The following is a description of a gene set: species: Homo sapiens Genes predicted to be targets of miRBase v22 microRNA hsa-miR-3160-3p in miRDB v6.0 with MirTarget v4 prediction scores > 80 (high confidence targets). Human Gene Set: MIR3160_3P from publication Chen Y, Wang X (PMID 31504780), and this is the list of marker genes: RAMAC, NAB1, DESI2, ALOX5AP, ZNF217, AP4B1, FAM153A, PDE7A, RPS6KB1, PCDH9, IFNA2, HOXA1, CROT, LYZ, FN1, MFSD9, C3orf70, ID4, C1orf174, REPS1, RUFY2, ACTBL2, NCOA3, FABP7, MAP3K9, SDHAF2, CUL3, RNF144A, CNOT1, SVIP, ST8SIA5, TSPYL6, UVSSA, RAB10, ATP8A1, LARP1B, YPEL5, ZC3H12C, ZNF699, BTBD19, DIXDC1, CRIM1, NSMCE3, LILRA4, TBL1Y, A1CF, RNF168, TFAM, LRRC75A, SLC6A13, ARL8A, ZZZ3, FMNL3, ADH1B, TMEM11, DEPTOR, CORO6, CNKSR2, GIPC3, PUS1, CHTF8, SLC8A1, XPO7, CREB3L1, VNN1, ZNF611, TET2, HIPK2, CSN3, TPRG1L